Given this list of marker genes NOVA1, ADAMTS8, SLC38A2, INA, SOX2, UBE2U, CILK1, SALL1, CSNK1A1, FAM78B, SH3D19, SAMHD1, MAPK8 (NCBI Gene Id 5599), NFAT5, CDIN1, BPTF, COPS7B, GOLT1B, ERCC4, VCPIP1, NTNG1, HBD (hemoglobin subunit delta, NCBI Gene Id 3045), SIAE, PPP1R3A, SPRING1, GEMIN8, MAK16, DR1, PPP1R1C, SLAIN2, GPR160, CD81, CA10, PTPRB, CDK13, CD59, PLA2G3, CRYZ, DNAJB9, MTM1, DNAJC21, ANKRD29, ENY2, PHTF2, LBH, PSENEN, ZDHHC9, UQCC3, RUNX2, CHKA, GRB2, MDM1, RASGRP3, EMC1, TRMT5, RC3H1, ARGLU1, SLC12A6, SP1, HDDC2, RAC1, KRIT1, ELOC, PLK2, TTC33, GTF2H1, UBP1, ZBTB8A, SSBP2, CPEB3, RELA, GOSR1 (NCBI Gene Id 9527), FUBP3, EMILIN3, RBM28, ITCH, CSNK1G3, RAB3C, ACVR2A, ZNF322, XRN2, SNRPF, DENND6A, CDR2, ATRAID, OGT, PIAS2, HEPN1, SPON1, TUT4, SETD2, ZNF292, PMEPA1 (prostate transmembrane protein, androgen induced 1), LEPROTL1, KALRN, RNF212B, SLC26A5, BAMBI, STAMBP, RNF13, ZBTB6, ANXA4, here is a description of the gene set: Human Gene Set: MIR5000_5P Genes predicted to be targets of miRBase v22 microRNA hsa-miR-5000-5p in miRDB v6.0 with MirTarget v4 prediction scores > 80 (high confidence targets). from publication Chen Y, Wang X (PMID 31504780) studied in species Homo sapiens